The following is a description of a gene set: studied in species Mus musculus Mouse Gene Set: GOTZMANN_EPITHELIAL_TO_MESENCHYMAL_TRANSITION_DN Genes down-regulated in MMH-RT cells (hepatocytes displaying an invasive, metastatic phenotype) during epithelial to mesenchymal transition (EMT). from publication Gotzmann J, Fischer AN, Zojer M, Mikula M, Proell V, Huber H, Jechlinger M, Waerner T, Weith A, Beug H, Mikulits W (PMID 16607286) Polarized hepatocytes expressing hyperactive Ha-Ras adopt an invasive and metastatic phenotype in cooperation with transforming growth factor (TGF)-beta. This dramatic increase in malignancy is displayed by an epithelial to mesenchymal transition (EMT), which mimics the TGF-beta-mediated progression of human hepatocellular carcinomas. In culture, hepatocellular EMT occurs highly synchronously, facilitating the analysis of molecular events underlying the various stages of this process. Here, we show that in response to TGF-beta, phosphorylated Smads rapidly translocated into the nucleus and activated transcription of target genes such as E-cadherin repressors of the Snail superfamily, causing loss of cell adhesion. Within the TGF-beta superfamily of cytokines, TGF-beta1, -beta2 and -beta3 were specific for the induction of hepatocellular EMT. Expression profiling of EMT kinetics revealed 78 up- and 235 downregulated genes, which preferentially modulate metabolic activities, extracellular matrix composition, transcriptional activities and cell survival. Independent of the genetic background, platelet-derived growth factor (PDGF)-A ligand and both PDGF receptor subunits were highly elevated, together with autocrine secretion of bioactive PDGF. Interference with PDGF signalling by employing hepatocytes expressing the dominant-negative PDGF-alpha receptor revealed decreased TGF-beta-induced migration in vitro and efficient suppression of tumour growth in vivo. In conclusion, these results provide evidence for a crucial role of PDGF in TGF-beta-mediated tumour progression of hepatocytes and suggest PDGF as a target for therapeutic intervention in liver cancer., and this is the list of marker genes: Pura, Hsd17b10, Gstm1, Man1a, Pparg, Rnf2, Klf4, Prkacb, Zfp36l1, Acadm, Scp2, Trp53, Amd1, Fhl1, Rock1, Prkg2, Slc3a2, Tfam, Hnrnph1, Gata5, Serpine2, Ap2a2, Cdkn2a, Bax, Tcea1, Egr1, Gdi2, Pam, Slc1a5, Serpinb6a, Mmp13, Srsf1, Vdac1, Ech1, Ywhaz, Fosl1, Tob1, Itgb4, Fnta, Sdc4, Ddx19a, Eps8, Ufd1, Pthlh, Il1r1, Xrn2, Ugt1a2, Alad, Stom, Aqp8, Ptprm, Clns1a, Psmc5, Anxa11, Hmmr, Tm4sf1, Klf3, Ppp1cb, Sod1, Gm14270 (NCBI Gene Id 20461), Polr2c (NCBI Gene Id 20021, polymerase (RNA) II (DNA directed) polypeptide C), Lgals9, Gas8, Cops5, Ppfibp2, Cftr, Ywhaq, Gja1, Eya2, Abcb1a, Cxcl5, Fkbp2, Cd53, Gnb5, Gnai1, Cbx1, Mthfd2, Ddost, Tmem165, Slc12a1, Gm36287, Calm2, Sec23a (SEC23 homolog A, COPII coat complex component), S100a13, Cdkn1a, Dbp, Elp5, Tkt, Lgals3, Mrc1, Krt15, Ostf1, Mcpt1, Kcnab1, Bnc1, Raly, Slc35a1, Foxa2, Pdcd2, Tcea3, Dmbt1, Atp5f1b, Phyh, Ctnnb1, Mrpl23, Pfn1, Ddx24, Mapk14, Tpd52, Pigf, S100a8, Npepps, Arf4, Oaz1, Cdh1, Slc22a18, Rpl18, Sos1, Hs3st1, Anxa8, Cpt2, Atp6v1e1 (ATPase, H+ transporting, lysosomal V1 subunit E1), Krt19, Mxi1, Noct, Enpp1, Ube2h, Eps15, Loricrin, Anxa7, H2-T10, H2-T23, Dynlt1b, Fdft1, Bcap31, Stac, Hells, Pigq, Nfkbia, Ntan1, Exoc7, Tpm3, Trim25, Pa2g4, Stip1, Atp6v1a, Atp5mc1, Plxna2, Srp14, Dok1, Aip, Lbp, Sprr1a, Sec22b, Cct3, Mcpt2, Ahcyl, H3f3a, Acadl, Rab18, Ivl, Tnnt2, Ptprr, Selenop, Cyp2j6, Sephs2, Cd55, Psme1, Ucp2, Nherf1, Cxcl1, Casp3, Penk, Klra2, Snap23, Cd82, Psmc1, Wt1, Cx3cl1, Il1rn (NCBI Gene Id 320052), Hccs, Tle1, Fxyd5, Stk3, Arhgdib, Myc, Hmga2, Fgfbp1, Top2a, Edn2, Capza2, Ywhah, Cnih1, Gss (NCBI Gene Id 98903), Gna11, Cpe, Hmbs, Fos, H2-K1, Btc, Cyp3a13, Itih2, Sdf2, Abcd3, Atf2, Gjb4, Gpd1, Ier2, Polr1d, Pfkl, Casp4, Gstp2, Clcn3